The following is a description of a gene set: Mouse Gene Set: GOMF_IMPORTIN_ALPHA_FAMILY_PROTEIN_BINDING species: Mus musculus Binding to a member of the importin-alpha family., and this is the list of marker genes: Golga2, Cdadc1, Ei24, Rb1, Kpnb1, Dhx9, Desi1, Tpx2, Ran